The following is a description of a gene set: Human Gene Set: GOBP_RRNA_BASE_METHYLATION studied in species Homo sapiens The addition of a methyl group to an atom in the nucleoside base portion of a nucleotide residue in an rRNA molecule., and this is the list of marker genes: SPOUT1, EMG1, METTL15, NSUN5, METTL16, BUD23, METTL15P1, FDXACB1 (ferredoxin-fold anticodon binding domain containing 1), NOP2, TRMT112